Given this list of marker genes CAMTA1, ADIPOR2, CTDSP1, HOXB8, PCDH19, PRKCE, UBE4B, PLP1, PHC1, SLC35B3, LPIN1, CUL1, NFIL3, AMMECR1, CHODL, TSC22D3, KIF1C, PLXNB1, WT1-AS, KIF2A, CUX2, PHF6, RSBN1, MYCL, UBE2Q1 (NCBI Gene Id 84110), KRR1, ZC3H7A, ALX1, SENP3, RAB22A, LEPROTL1, LRRC1, MAP3K8, PIK3AP1, CBLIF, PPP1CB, SLITRK5, TAF5L, TOGARAM1, TNNI2, RPGRIP1L, SYT7, MCU, ZIC4, USP12, CLK2, CELSR2, NEXMIF, PURA, HES5 (NCBI Gene Id 388585), RCN1, NR4A3, BCLAF1, MEF2C (myocyte enhancer factor 2C), RABGEF1, VDAC2, ADCYAP1, SOX11, SYNJ1, RNF11 (ring finger protein 11), CTDSPL2, PITX2, PDK1, UBAP1, ERRFI1, KLHL14, RGL1, SATB2, CD164, PPP6R3, APOLD1, CDK2AP1, ATP6V1H, SCN3A, MYB, PPP2R5E, KCNRG, JUN, SOX4, SGPP1, SPOPL, CCDC140, CACHD1, WDFY3 (NCBI Gene Id 23001), NFIX, ACADSB, TRIM39, JADE3, SRSF2, ZMYM5, ELAVL4, DCX, ACACA, CLK1, ZBTB18, RET, SLC25A3, BCL6, C8orf82, NFASC, RDX, SYNC, MAP2K1, LPGAT1, KCND2, HAS2, CELF2, SEPHS1, NPR3, ROBO2, NR2F2, GRB10, PNN (pinin, desmosome associated protein), MYLK, LARP1, ALS2, DNAJB12, QKI, SNAP29, WIPF2, SMC1A, RASL10B, TAPT1, PPP4R3A, SRR, H2AX, TOMM70, here is a description of the gene set: Genes having at least one occurence of the motif AAAGGAT in their 3' untranslated region. The motif represents putative target (that is, seed match) of human mature miRNA hsa-miR-501 (v7.1 miRBase). Human Gene Set: AAAGGAT_MIR501 species: Homo sapiens